Given this list of marker genes NRAS, PPP3R1, NFATC3, PSMB3, NFATC1 (nuclear factor of activated T cells 1), REL, PSMA5, PSMD8, IKBKG, UBB, PSMD7, PSMA1, PSMB1, SEM1, CHUK, PSMC4, SKP1, CALM1, PSMD2, RASGRP3, BTRC, PSMB2 (proteasome 20S subunit beta 2), PSMA6, KRAS, HRAS, PSMD3, PSMC2, PPIA, PSMC6, NFKBIB, NFKBIE, BCL10, PSMA3, FBXW11, UBC, CARD11, PSMA4, PPP3CA, PSMB6, RPS27A, PSMD14, PPP3CB, PSMB4, PSMB5, PSMA7, FKBP1A, UBA52, RELA (NCBI Gene Id 5970), PSMD11, ADRM1, NFKBIA, IKBKB, PSMD1, PSMA2, PSMC5, PRKCB, RASGRP1, PSMD12, CUL1, PSMC3, PSMC1, MAP3K7, MALT1, PSMD13, NFATC2, PSMB7, PSMD6, NFKB1, here is a description of the gene set: Downstream signaling events of B Cell Receptor (BCR) Human Gene Set: REACTOME_DOWNSTREAM_SIGNALING_EVENTS_OF_B_CELL_RECEPTOR_BCR species: Homo sapiens